The following is a description of a gene set: species: Mus musculus Mouse Gene Set: GOMF_INTERLEUKIN_11_RECEPTOR_ACTIVITY Combining with interleukin-11 and transmitting the signal from one side of the membrane to the other to initiate a change in cell activity., and this is the list of marker genes: Il11ra2, Il6st, Cntfr, Il11ra3, Il6ra (interleukin 6 receptor, alpha), Il11ra1